The following is a description of a gene set: part of: Protein ubiquitination This event has been computationally inferred from an event that has been demonstrated in another species.<p>The inference is based on the homology mapping from PANTHER. Briefly, reactions for which all involved PhysicalEntities (in input, output and catalyst) have a mapped orthologue/paralogue (for complexes at least 75% of components must have a mapping) are inferred to the other species. Reactome Pathway: Synthesis of active ubiquitin: roles of E1 and E2 enzymes electronically inferred by orthology from the curated human pathway studied in species Mus musculus, and this is the list of marker genes: Uba1, Rps27a, Ube2e1, Ube2e3, Cdc34, Ubb, Ube2d1, Uchl3, Ube2c, Ube2r2, Ube2k, Ube2g1, Usp5, Ube2w, Ube2s